The following is a description of a gene set: Complete right bundle branch block Human Gene Set: HP_COMPLETE_RIGHT_BUNDLE_BRANCH_BLOCK A conduction block of the right branch of the bundle of His. This manifests as a prolongation of the QRS complex (greater than 0.12 s) with delayed activation of the right ventricle and terminal delay on the EKG. studied in species Homo sapiens, and this is the list of marker genes: DSG2, HCN4, MYH6, CACNB2, GYG1, SLMAP, KCNE3, SEMA3A, FHL1, AKAP9, CACNA2D1, SMCHD1, JUP, KCNJ8, FRG1, RNASEH1, EXOSC5, DUX4, TLL1, LEMD2, SCN5A, SCN3B (NCBI Gene Id 55800), KCNK3, PIGU, MYH7, GPD1L, DUX4L1, ACTC1, LMOD2, TNNI3K, MT-CYB, DYSF, NPPA, SCNN1A, POMT2 (NCBI Gene Id 29954), ABCC9, TNNC1, CNBP, SCN10A, FLNC, GNAI2, SCN2B, DNMT3B, PPP1CB, CITED2 (NCBI Gene Id 154106), KCND3, PKP2, SCN1B, TRPM4, TNNT2, KCNE5, RANGRF, MYBPC3, BANF1 (barrier to autointegration nuclear assembly factor 1), PLEC, ATP6V1E1, CACNA1C